Given this list of marker genes Pcdh10, Wdr90, Kcne2, Pde1c, Ptpn4, Tafa4, Cyp4a14, Rasa2, Trak2, Cyp4a31, Slc9a9, Ubl5, Tmtc2, Mrpl51, Gskip, 1810024B03Rik, D630039A03Rik, Tfcp2, Has2, Dcps, Zfp367, Tmprss15, Mgat4a, Zfp268, Usp15, Akr1c14, Fyb2, Atp5f1a, Txndc9, Ctsq, Fgd4, Pfdn4, Cxcl3 (NCBI Gene Id 330122), Mthfd2l, Slk, Slain2, Cenpf, Atl2, Sema4g, Sema3d (NCBI Gene Id 74345), Sdk1, Tmem169, Bet1, Ube2d3, Clasp2, Rims2, Pdlim5, Slco1b2, Alg13, Dip2b, Serpina3b, Oaz2, Gnai2, Pianp, Fry, Col5a1, Atp2a2, Itpr1, Prg4, Cyp4a10, Itga9, Ssbp2, Fzd7, Osbpl2, Tyrp1, Wdr44, Fmr1, Acad12, here is a description of the gene set: Genes predicted to be targets of miRBase v22 microRNA mmu_miR_6902_3p in miRDB v6.0 with MirTarget v4 prediction scores > 80 (high confidence targets). from publication Chen Y, Wang X (PMID 31504780) Mouse Gene Set: MIR_6902_3P species: Mus musculus